The following is a description of a gene set: species: Homo sapiens Human Gene Set: WHITFIELD_CELL_CYCLE_G1_S Genes periodically expressed in synchronized HeLa cells (cervical carcinoma), with peak during the G1/S phase of cell cycle. The genome-wide program of gene expression during the cell division cycle in a human cancer cell line (HeLa) was characterized using cDNA microarrays. Transcripts of >genes showed periodic variation during the cell cycle. Hierarchical clustering of the expression patterns revealed coexpressed groups of previously well-characterized genes involved in essential cell cycle processes such as DNA replication, chromosome segregation, and cell adhesion along with genes of uncharacterized function. Most of the genes whose expression had previously been reported to correlate with the proliferative state of tumors were found herein also to be periodically expressed during the HeLa cell cycle. However, some of the genes periodically expressed in the HeLa cell cycle do not have a consistent correlation with tumor proliferation. Cell cycle-regulated transcripts of genes involved in fundamental processes such as DNA replication and chromosome segregation seem to be more highly expressed in proliferative tumors simply because they contain more cycling cells. The data in this report provide a comprehensive catalog of cell cycle regulated genes that can serve as a starting point for functional discovery. The full dataset is available at http://genome-www.stanford.edu/Human-CellCycle/HeLa/. from publication Whitfield ML, Sherlock G, Saldanha AJ, Murray JI, Ball CA, Alexander KE, Matese JC, Perou CM, Hurt MM, Brown PO, Botstein D (PMID 12058064), and this is the list of marker genes: ARGLU1, RAB23, ZMYND19 (zinc finger MYND-type containing 19), TREX1, MNT, ACD, PANK2, ESD, KIAA1586, CHAF1B, TCAF1, MCM2, CCDC180, DIS3, MNX1, E2F1, ZRANB2, NSUN5P2, SSR3, NEAT1, DTL, GINS3, BAIAP2, DNAJC3, SERPINB3, MDM1, ORC1, TMEM243, HSPB8, NASP, RNF113A, ABCA7, UHRF1, ATAD2, INTS8, CDC25A, ADCY6, TOPBP1, FAM111B, CDC6, TRMT2A, ANKRD10, SKP2, HCG18, CTSD, INAFM2, E2F2, HOXB4, HSF2, TSPEAR-AS1, GON7, EIF2A, CASP2, RSRP1, MBOAT1, FLAD1, PASK, BARD1, AP3M2, ORMDL1, PDXP, PCNAP1, MSH2, IVNS1ABP, ZNF367, FBXL20, SLBP, MAP2K6, CCNE1, FANCG, CREBZF, RUNX1, APEX2, NKTR, TAF15, SRSF7, AP4B1, DSCC1, BRD7, RMI2, NUP43, HRAS, DENND11, CHAF1A, TIPIN (NCBI Gene Id 54962), CDCA7L, UNG, TTC14, RNPC3, DDX12P, SEC62, CLSPN, NPAT, PCNA, POLD3, OSBPL6, KANK2, TONSL-AS1, DHFR2, CDCA7, UBR7, PABIR1, GMNN, PNN, ADCK2, VPS72, SPIN4, SLC25A36, MCM5, GINS2, ADAMTS1, CCNE2, MRI1, USP53, CASP8AP2 (caspase 8 associated protein 2), SDC1, CDK20, MED31, WDR76, LNPEP, ZNF414, TRA2A, PLCXD1, MCM4, ACYP1, RECQL4, SPIN3, KCNC4, CAPN7, MCM6, TRIM45, HORMAD1, OTULIN